Given this list of marker genes GSTK1, ENTPD2, SLC25A20, FOXP1, ATP5F1E, GHITM, ITGA4, CD72, KRT33A, GJB3 (gap junction protein beta 3), TAX1BP1, LHX5, TAF7, MT2A, GPBP1 (NCBI Gene Id 65056), DUSP1, AEBP2, SLC25A37, ACTRT1, CD86, MX1, PWP1, MRPS6, LTA, TLE1, XCL1, PLAT, PRPF40A, RTP4, TNFSF10, REL, FOXJ3, CDC42EP4 (NCBI Gene Id 91740), KLF3, RNF208, ZRSR2, RCN1, METRNL, IRF8, STK17B, P2RY2, RFFL, KCNA3, KBTBD2, HTRA2, GLRA3, GIMAP1, SPTAN1, P3H3, DNAJB6, PLCL2, RND3, MRE11 (MRE11 homolog, double strand break repair nuclease), PTCH1, FABP4, FANCC, TASOR2, OLR1, ZBTB32, OFD1, GBP7, GALNT3, TMEM191C, PKMYT1, DLK2, CDKN1A, TPMT, KCTD10, KLF9, VCAN (versican), TRAF1, DUSP26, DENR, ACTN1, KREMEN1, RAB38, VWA5A, ODR4, UBE2H, SMARCE1, ZSWIM9, FOS, ARMCX3, MXD1, JAG1, NEDD9, CA13, SMAD1, SYT13, BHLHE41, GRID2, SH3BP4, MMD, SLC7A11, KLHL25, SCAND1, GAS7, IL10, TIMP4, PKNOX2, MED21, SHCBP1, LYZL4, CHRND, ARHGAP31, GYPC, CD200, HMGB1, FAM107B, NFATC1, SMARCB1, SLC38A1 (NCBI Gene Id 81539), AP3M2, PDPN, MDFIC, CLDN5, ADCY8, AZIN1 (antizyme inhibitor 1), ETV6, KTN1, AKR1D1, AOX1, KRT33B (NCBI Gene Id 3884), PMEPA1, FAM133B (family with sequence similarity 133 member B), ADM, IFITM2 (NCBI Gene Id 10581), RAB30, PPIB, JUN, PABIR1, COLEC12 (collectin subfamily member 12), BFSP1, NFKBIB, SERPING1, ETS2, ARG2, REPIN1, GPR137B, PDLIM4, PSPC1, LAMTOR2, NPM1, PLG, LTBP3, TJP2 (NCBI Gene Id 9414), TMEM39A, PLSCR1, FOXF2, EPC1, IFT57, RILPL2, SIN3B (SIN3 transcription regulator family member B), EPHB3, LOX, GRHL1, IFRD1, FEM1B, HPGDS, CXCL11, PDLIM5, SERPINB9, GADD45B, SLC25A17, PIWIL2, KMT2D, DSCAML1, CXCR3, CST8, CA4, PRNP, CPSF4L, SPRYD7 (SPRY domain containing 7), IL20, HNRNPLL, MEF2A, TGIF1, HTRA1, CHIC2, SMS, WDR48, ANXA7, SLC12A4, IRS2, GUCY1A1, GPR85, STAT4, CCL13, EIF1, CALCRL, YES1, PI15, KDM5C, ICAM1 (NCBI Gene Id 3383), CS, GDF9, SPRY1, ZNF296, NFKBIZ, ACSL1 (NCBI Gene Id 91249), here is a description of the gene set: mouse primary BMDCs were stimulated with tlr ligands and gene expression changes were profiled on Affymetrix arrays from publication Amit I, Garber M, Chevrier N, Leite AP, Donner Y, Eisenhaure T, Guttman M, Grenier JK, Li W, Zuk O, Schubert LA, Birditt B, Shay T, Goren A, Zhang X, Smith Z, Deering R, McDonald RC, Cabili M, Bernstein BE, Rinn JL, Meissner A, Root DE, Hacohen N, Regev A (PMID 19729616) Genes up-regulated in comparison of dendritic cells (DC) stimulated with LPS (TLR4 agonist) at 2 h versus DC cells stimulated with Gardiquimod (TLR7 agonist) at 2 h. species: Homo sapiens Human Gene Set: GSE17721_LPS_VS_GARDIQUIMOD_2H_BMDC_UP